The following is a description of a gene set: from publication Huh JR, Leung MW, Huang P, Ryan DA, Krout MR, Malapaka RR, Chow J, Manel N, Ciofani M, Kim SV, Cuesta A, Santori FR, Lafaille JJ, Xu HE, Gin DY, Rastinejad F, Littman DR (PMID 21441909) species: Homo sapiens Human Gene Set: GSE27241_CTRL_VS_DIGOXIN_TREATED_CD4_TCELL_IN_TH17_POLARIZING_CONDITIONS_UP Genes up-regulated in polarizing CD4 Th17 cells: untreated versus digoxin. CD4+ T helper lymphocytes that express interleukin-17 (Th17 cells) have critical roles in mouse models of autoimmunity, and there is mounting evidence that they also influence inflammatory processes in humans. Genome-wide association studies in humans have linked genes involved in Th17 cell differentiation and function with susceptibility to Crohn’s disease, rheumatoid arthritis, and psoriasis1-3. Thus, the pathway towards differentiation of Th17 cells and, perhaps, of related innate lymphoid cells with similar effector functions4, 5, is an attractive target for therapeutic applications. Mouse and human Th17 cells are distinguished by expression of the retinoic acid receptor-related orphan nuclear receptor RORγt, which is required for induction of IL-17 transcription and for the manifestation of Th17-dependent autoimmune disease in mice6. By performing a chemical screen with an insect cell-based reporter system, we identified the cardiac glycoside digoxin as a specific inhibitor of RORγt transcriptional activity. Digoxin inhibited murine Th17 cell differentiation without affecting differentiation of other T cell lineages and was effective in delaying the onset and reducing the severity of autoimmune disease in mice. At high concentrations, digoxin is toxic for human cells, but non-toxic synthetic derivatives, 20,22-dihydrodigoxin-21,23-diol (Dig(dhd)) and digoxin-21-salicylidene (Dig(sal)), specifically inhibited induction of IL-17 in human CD4+ T cells. Using these small molecule compounds, we demonstrated that RORγt is imporant for the maintenance of IL-17 expression in mouse and human effector T cells. These data suggest that derivatives of digoxin can be used as chemical probes for development of RORγt-targeted therapeutic agents that attenuate inflammatory lymphocyte function and autoimmune disease., and this is the list of marker genes: FAM124B, RAPH1, CERS4 (ceramide synthase 4), UBE2D3, ABI2, DDX17, SRFBP1 (NCBI Gene Id 153443), FPR1, GTF2A1L, CHD4, TADA1, STAT6, RELB, CREB1, SH3BP2, NAB2, MIR222, PER1 (NCBI Gene Id 5187), DEDD, NDFIP1, PPP1R15A, LCE1C, ADAM15, TNIP2, ATG16L1, IL13, PARP14, MLXIP, SLC44A2, CTSC, CD69, BATF, POLG, TLE1, ELK4, IL3RA, NFKB2, SHISA5, DOP1B, YAF2, PTGER4, GPR83, ADAMTSL4, ARAP2, LTA (NCBI Gene Id 4049), NFKBIZ, ST14, TGIF1, PRDM15, EPHX1, PATZ1 (NCBI Gene Id 23598), AGO2, FLACC1, CLNK, SAMSN1, SNORA30 (NCBI Gene Id 677813), ARID5B (AT-rich interaction domain 5B), EGR1, TRIB1, VPS13D, CXCL9, CSNK1G3, PRDM14, S100PBP, IL21R, ETV3, NCOA3, BAZ1A, ICAM1, LHFPL7, SLC39A2, PRR9 (proline rich 9), STX11, HEATR1, PDCL2, DUSP2, TWF1, TRA2A, PDE7A, TGIF2, NAB1 (NGFI-A binding protein 1), MARCHF1, PTH1R, SSH2, GADD45B, KIF21B, NFKBIA, CCNT1, B3GNT3, TAGAP, CISH, XCL1, PLIN2, TUT1, MINDY3, MAP3K8, UBASH3A, ESYT2, ARHGAP4, SAFB (NCBI Gene Id 6294), HSPA4L, EFL1, MEFV, ZHX2, RELA, NDRG1, DBNDD2, MYOM2, CXCR2, SNRNP70, NR4A1, GRAMD1A, NFKBID, PDCD1, BIRC3, RNF19A, KLF13, MDM4, ATG16L2, NFKB1, IL12B, NR4A3, IER3, KLHL26, BCL2L11, EGR2, PTPN6, MIR130B, CXCL10, ARF3, ETNK1, MIR155, RASAL2, SDAD1 (SDA1 domain containing 1), PSD, GSAP, GPR18, CD274, ENTR1, ARL5B, ZC3H12A, PPP1R3D, ANKRD13C, REL, TCF7, REG4, FOS, IL27RA, LCAT, GPR183, KAT6A (lysine acetyltransferase 6A), PLK2, IRF3, TSPYL2, TNFAIP3, BTLA, CPT1A, MCAM, PLCL2, PLB1, TTC19, WASL